The following is a description of a gene set: Human Gene Set: GOBP_EXOCRINE_SYSTEM_DEVELOPMENT studied in species Homo sapiens Progression of the exocrine system over time, from its formation to a mature structure. The exocrine system is a system of hormones and glands, where the glands secrete straight to a target site via ducts or tubes. The human exocrine system includes the salivary glands, sweat glands and many glands of the digestive system., and this is the list of marker genes: EDAR, TGFB1, TGFB3, BTBD7, PLXNA1, IGF1, SOX9, IGSF3, ESRP2, NTN4, IGF2, PDX1, FGF7, TFCP2L1, SHH, HGF, PTF1A, INSR, TNF, EDA, PAX6, RAB26, TWSG1, NRP1, EGFR, FGF8, SRP54, BMP7, SOX10, FOXC1, CLCN2 (NCBI Gene Id 79179), ASCL3, XBP1, DAG1, FGF10, WLS, TGM2, SNAI2, NFIB (nuclear factor I B), PDGFA, LAMA1, FGFR1, TGFB2, PLXND1, LAMA5, NR5A2, CELA1, FGFR2, POLB, NKX3-1, SEMA3C